The following is a description of a gene set: Reactome Pathway: Processing and activation of SUMO This event has been computationally inferred from an event that has been demonstrated in another species.<p>The inference is based on the homology mapping from PANTHER. Briefly, reactions for which all involved PhysicalEntities (in input, output and catalyst) have a mapped orthologue/paralogue (for complexes at least 75% of components must have a mapping) are inferred to the other species. part of: SUMOylation electronically inferred by orthology from the curated human pathway studied in species Mus musculus, and this is the list of marker genes: Senp2, Sumo1 (small ubiquitin-like modifier 1), Rwdd2b